The following is a description of a gene set: studied in species Mus musculus Mouse Gene Set: GOBP_GLYCOSPHINGOLIPID_METABOLIC_PROCESS The chemical reactions and pathways involving glycosphingolipids, any compound with residues of sphingoid and at least one monosaccharide., and this is the list of marker genes: Lct, St6galnac4, Glb1, A4galt, Fa2h, Map7, Gba1, Neu2, Galc, St8sia6, Fut9, Neu3, Ugt8a, B3galt1, B4galt4, Itgb8, Neu1, Naglu, Bax, 6430550D23Rik, Kit, Prkcd, B4galt3, St8sia2, St6galnac1, Fut4, Hexa, Gm2a, Tm9sf2, St6galnac5, Abca2, Psap, B4galnt1, St8sia5, Neu4, Cln6, B3galt4, B4galt5, Hexb, Gba2, St6galnac3, St3gal3, A3galt2, B3galt2, St3gal2, St8sia4, Gbgt1, Ugcg, Gal3st1, St6galnac6, St3gal1 (ST3 beta-galactoside alpha-2,3-sialyltransferase 1), St8sia3, Crem, B4galt6 (NCBI Gene Id 56386), Gla